Given this list of marker genes POLG, MYH6, CASQ2, CACNA2D1, KCNH2, CACNA1C, GATAD1, DMPK, EMD, RYR2, ACTC1, PLN, NKX2-6, KCNJ3, TMEM43, APRT, MYPN, ZFHX3, FHOD3, KIF20A, SCN1B, NUP155, TNNI3, CLIC2, SLC25A4 (solute carrier family 25 member 4), TLL1, NKX2-5, PRKAG2, RRM2B, TTR, KCNQ1 (NCBI Gene Id 3784), TNNT2 (NCBI Gene Id 7139), GNB2, DBH, KCNJ5, TBX5, MYL4, PSEN2, CALM3 (NCBI Gene Id 808), TNNC1, CACNB2, ABCC9, CALM2, LMOD2, GATA4, CAVIN1, DTNA, MYOZ2, GATA6, CORIN, TTN, FLNC, TAB2, LAMP2, KCNK3, POLG2, KCNE1, TWNK, JPH2, XK (NCBI Gene Id 7504), SLC4A3, GJA5, PITX2 (paired like homeodomain 2), SCN5A, SGO1, NPPA, HCN4, MFAP5, MYH7, TECRL, CITED2, SCN3B, TNNI3K, KCNE2, TRDN, CSRP3, NEXN, KCNA5, TPM1, NODAL, LMNA, CALM1, MT-CYB, SMAD3, ANK2, KCNJ2, LRP12, ACTN2, CAPNS1, SCN4B, GATA5, SCN2B, TBX20, here is a description of the gene set: A type of supraventricular tachycardia in which the atria are the principal site of electrophysiologic disturbance. Human Gene Set: HP_ATRIAL_ARRHYTHMIA species: Homo sapiens Atrial arrhythmia